The following is a description of a gene set: Human Gene Set: MIR6775_5P from publication Chen Y, Wang X (PMID 31504780) studied in species Homo sapiens Genes predicted to be targets of miRBase v22 microRNA hsa-miR-6775-5p in miRDB v6.0 with MirTarget v4 prediction scores > 80 (high confidence targets)., and this is the list of marker genes: SSUH2, CASR, FGF23, HASPIN, IL2RG, ZRANB2